The following is a description of a gene set: studied in species Mus musculus The developmental process pertaining to the initial formation of a nephric duct. A nephric duct is a tube that drains a primitive kidney. Mouse Gene Set: GOBP_NEPHRIC_DUCT_FORMATION, and this is the list of marker genes: Hnf1b, Mir216b, Mir216a, Bmp4, Mir217, Pax2, Wnt9b, Gata3